Given this list of marker genes TNFSF4, HLA-DRA, IL23R, CD46, HLA-DRB1, IL12B, IL12RB1, PCK1, IL23A, here is a description of the gene set: studied in species Homo sapiens Human Gene Set: GOBP_POSITIVE_REGULATION_OF_MEMORY_T_CELL_DIFFERENTIATION Any process that activates or increases the frequency, rate or extent of memory T cell differentiation.